The following is a description of a gene set: species: Mus musculus Mouse Gene Set: GOBP_PHOSPHOLIPASE_C_ACTIVATING_DOPAMINE_RECEPTOR_SIGNALING_PATHWAY A phospholipase C-activating receptor G protein-coupled receptor signaling pathway initiated by dopamine binding to its receptor on the surface of a target cell, and ending with the regulation of a downstream cellular process, e.g. transcription., and this is the list of marker genes: Gnaq, Drd2, Drd3, Nherf1, Gna14, Drd1, Drd4, Gna15, Gna11